Given this list of marker genes KATNB1, APRT, SCNN1A, ERMN, RNF168, MICOS13, SELENOH, ZNF112, AATBC, NHERF4, RRN3P3, ZMYM2, CLK4 (NCBI Gene Id 57396), PIK3C3, DLST, TSPYL1, LGALS2, TOB1, DENND5B, LEMD3, OSBPL8, SNAPC5, SLC40A1, IDH3B, KLRA1P, EIF4B, ALDH9A1, METRN, TGM3, NKX3-2, KLF9, ENO3, NUDT16, UHRF1, KICS2, RBM46, PTCH1, MTBP, MATCAP2, KLHL31, HNRNPA3, SELENOP, CEP295, C2orf68, HECA, NKAP, C16orf92, CSDE1, DTL, KANK2, PEX14, FTX, CAMSAP3, CEP120, TTC22, HMG20A, SERINC3, RXRB, ZNF623, TNFRSF10A, PIGG, RPN1, SLC7A7, PKD1, MANSC1, ENSG00000124835, TECR, MATR3, SORBS2 (sorbin and SH3 domain containing 2), SMAD6, LINC01354, CSTF2T, SLC25A36, NRIP1, SLC3A1, LNPEP, HOXC9, LINC02381, CFAP69, NUCB2, HIBCH, TERF2IP, LINC01098, MAP3K7, UNG, ZNF514, DCDC2B, FAM117A, C1orf210, DHX15, LINC00938, ZBTB7C-AS2, TRIM7, RNF141, CDCA7L, GATB, USP37, CCDC127, MAOA, CLK1, UBN1, PPOX, CPLANE2, CTPS2 (NCBI Gene Id 95807), DDX39B, GADD45GIP1, AKR1E2, SHARPIN, IPP, AASDHPPT, OR10R2, ATXN10, SESTD1, TEP1, GULP1, TMEM129, AVEN, SIGLEC8 (sialic acid binding Ig like lectin 8), NUPR1 (NCBI Gene Id 26471), CAMK2N1, ZNF280C, ADSS2, YTHDC2, TARS3, HOXC6, ZNF143-AS1, TMEM42, GOLIM4, ARL2, RYK, SLC30A9, FOXO1, CEBPB, COBLL1, SPAG16, IGF2BP3, AKAP10, ALG1, ZNF738, ZNF570, ZHX1, WEE1, LFNG, CRNDE, PSME2, GABPB1-IT1, ACBD3, ASCL2, TTLL11, TMEM132D, FRMD8, PSMC5, CIR1, FARP1, ASH1L-AS1 (NCBI Gene Id 648965), LRIG3, BCLAF1, HES1, ZNF252P, HOOK1, C2orf74, CELF1, LRRC37A16P, ZNF692, OSBPL2, PRSS58, ANP32E, CCDC150, GXYLT1, LINC00656, SRSF10, PLEKHA5, MARCHF8 (NCBI Gene Id 220972), EXOSC7 (NCBI Gene Id 23016), FIGNL1, SOS2, HOXA10, NAXD, HMGCL, RAD17, TRAPPC14, IRF2BPL, FNBP1L, AGBL2, IL34, WWC2, STX16, YIPF4, UPF2 (UPF2 regulator of nonsense mediated mRNA decay), TENM1, PDE11A, SYNJ2BP, NUDT12, LINC00290, YY1AP1 (YY1 associated protein 1), here is a description of the gene set: species: Homo sapiens Abstract of publicaton: CD4/CD8 double-positive (DP) thymocytes express the transcriptional repressor Histone Deacetylase 7 (HDAC7), a class IIa HDAC that is exported from the cell nucleus after T cell receptor (TCR) engagement. Through signal-dependent nuclear export, class IIa HDACs such as HDAC7 mediate signal-dependent changes in gene expression that are important to developmental fate decisions in multiple tissues. We report that HDAC7 is exported from the cell nucleus during positive selection in thymocytes, and regulates genes mediating the coupling between TCR engagement and downstream events that determine cell survival. Thymocytes lacking HDAC7 are inefficiently positively selected due to a severely shortened lifespan and exhibit a truncated repertoire of TCR Jalpha segments. The expression of multiple important mediators and modulators of the response to TCR engagement is altered in HDAC7-deficient thymocytes, resulting in increased tonic MAP kinase activity that contributes to the observed loss of viability. Remarkably, the activity of Protein Kinase D, the kinase that mediates nuclear export of HDAC7 in response to TCR signaling, is also increased in HDAC7-deficient thymocytes, suggesting that HDAC7 nuclear export governs a self-sustaining auto-excitatory loop. These experiments add to the understanding of the life/death decision in thymic T cell development, define a novel function for class IIa HDACs, and point to a novel feed-forward mechanism whereby these molecules regulate their own state and mediate stable developmental transitions. Title of manuscript: Nuclear Export of Histone Deacetylase 7 During Thymic Selection Mediates Immune Self-tolerance. abstract of manuscript: Histone Deacetylase 7 (HDAC7) is a TCR signal-dependent regulator of differentiation that is highly expressed in CD4/CD8 double-positive (DP) thymocytes. Here we examine the effect of blocking TCR-dependent nuclear export of HDAC7 during thymic selection, through expression of a signal-resistant mutant of HDAC7 (HDAC7-delta-P) in thymocytes. We find that HDAC7-delta-P Transgenic thymocytes exhibit a profound block in negative thymic selection, but can still undergo positive selection, resulting in the escape of autoreactive T cells into the periphery. Gene expression profiling reveals a comprehensive suppression of the negative selection-associated gene expression program in DP thymocytes, associated with a defect in the activation of MAP kinase pathways by TCR signals. The consequence of this block in vivo is a lethal autoimmune syndrome involving the exocrine pancreas and other abdominal organs. These experiments establish a novel molecular model of autoimmunity and cast new light on the relationship between thymic selection and immune self-tolerance. Goal of Microarray experiment: We did these experiments to determine how alteration of the function of HDAC7, a site-specific and signal-dependent repressor of transcription, changes gene expression in CD4/CD8 DP thymocytes. Human Gene Set: GSE26488_WT_VS_HDAC7_KO_DOUBLE_POSITIVE_THYMOCYTE_UP from publication Kasler HG, Young BD, Mottet D, Lim HW, Collins AM, Olson EN, Verdin E (PMID 21398603) Genes up-regulated in double positive thymocytes: wildtype versus HDAC7 knockout.